The following is a description of a gene set: The developmental growth in which the ureteric bud grows along its axis beginning with the growth of the primary ureteric bud and ending when the branches of the bud have elongated. Mouse Gene Set: GOBP_URETERIC_BUD_ELONGATION species: Mus musculus, and this is the list of marker genes: Sall1, Kif26b, Fmn1, Hnf1b, Fgf1, Lzts2, Six4, Six1 (sine oculis-related homeobox 1)